Given this list of marker genes GATA6, ATF2, MIR134, MIR204 (NCBI Gene Id 406987), MIR10A, MEIS2, MALAT1, here is a description of the gene set: species: Homo sapiens Human Gene Set: GOBP_CARDIAC_MUSCLE_MYOBLAST_PROLIFERATION The multiplication or reproduction of cardiac muscle myoblasts, resulting in the expansion of a cardiac muscle myoblast cell population. A cardiac myoblast is a precursor cell that has been committed to a cardiac muscle cell fate but retains the ability to divide and proliferate throughout life.